The following is a description of a gene set: Mouse Gene Set: GOBP_AMINO_ACID_BETAINE_BIOSYNTHETIC_PROCESS The chemical reactions and pathways resulting in the formation of any betaine, the N-trimethyl derivative of an amino acid. species: Mus musculus, and this is the list of marker genes: Acadm, Bbox1, Chdh, Aldh7a1, Aldh9a1